The following is a description of a gene set: Human Gene Set: GOBP_SULFUR_COMPOUND_TRANSPORT species: Homo sapiens The directed movement of compounds that contain sulfur, out of or within a cell, or between cells, by means of some agent such as a transporter or pore., and this is the list of marker genes: SLC1A1, NFE2L1, MFSD12, LRRC8D (leucine rich repeat containing 8 VRAC subunit D), SLC26A11, GJA1, SLC33A1, SLC1A2, SLC35F3, SLC6A6, SLC7A9, SLC35B3, SLC27A1, SLC7A5, SLC47A1, SLC44A4, ABCD1, SLC6A13, SLC25A47, SLC16A6, SLC25A16, ABCC5, SLC3A2, SLC25A26, SLC1A4, SLC13A3, SLC26A3, SLC6A11 (solute carrier family 6 member 11), RACGAP1, LRRC8A, ABCC4, SLC26A6, SLC26A9, SLC26A5, SLC13A1, SLC26A8, SLC7A11, SLC26A10P, SLC43A2, NHERF1, CTNS, SLC25A10, SLC25A39, ABCC1 (NCBI Gene Id 8133), SLC22A1, SLC25A40, UCP2 (NCBI Gene Id 7351), SLC26A7, SLC7A13, SLC13A4, LRRC8C, SLC25A42, SLC25A19, SLC35B2, ABCG2, SLC25A17, MGST1, SLC36A1, SLC26A2, SLC5A6, SLC19A3 (NCBI Gene Id 80704), SLC26A1, SLC22A2 (NCBI Gene Id 6582), SLC19A2, SLC3A1, SLC26A4